The following is a description of a gene set: studied in species Homo sapiens Human Gene Set: REACTOME_REGULATION_OF_LOCALIZATION_OF_FOXO_TRANSCRIPTION_FACTORS Regulation of localization of FOXO transcription factors, and this is the list of marker genes: FOXO3, FOXO4, YWHAZ, YWHAQ, YWHAB, AKT1, SFN, FOXO6, YWHAG, FOXO1, AKT3, AKT2